Given this list of marker genes Mndal, Ifit3, Ppa1, H2-T22, Tapbpl, H2-T23, Tap2, Gbp5, Rnf114, Ube2l6, Irf1, AI987944, Lgals3bp, Xaf1, Cops3, Isg15, Igtp, Irf8, Samhd1, Tmem128, Socs1, Phtf2, Apobec3, H2-D1, Gbp6, Gbp3, Nmi, Serpina3g, Ifit1bl1, Irgm2, Tmsb10, Isg20, Psme2b, Ifi27l2a, Plaat3, Ifi47, Parp14, Stat1, Gbp8, Stat2, H2-Q4, Psmb10, Gbp9, Usp18, Bst2, Gimap3, Gimap4, Gbp4, Ly6e (NCBI Gene Id 17069), Phf11b, Gbp7, Irf7, Ifi213, Psme1, Idnk, Psmb9, H2-K1, Ifit1, Dbnl, Iigp1, Calhm6, Evl, Zbp1, Arl6ip5, B2m, Gbp2 (guanylate binding protein 2), Rnf213, Irgm1, Psme2, Tspan3, Psmb8, Irf9, Dtx3l, Cwf19l2, Tap1, Ifi206, Tapbp (NCBI Gene Id 28066), Parp9, Ly6a, here is a description of the gene set: Genes positively differentially expressed in cell type: Treg upon treatment with cytokine: IFN-γ in mouse lymph nodes in vivo. Mouse Gene Set: CUI_TREG_IFNG_RESPONSE_UP Cytokines mediate cell-cell communication in the immune system and represent important therapeutic targets. A myriad of studies have highlighted their central role in immune function, yet we lack a global view of the cellular responses of each immune cell type to each cytokine. To address this gap, the authors created the Immune Dictionary, a compendium of single-cell transcriptomic profiles of more than 17 immune cell types in response to each of 86 cytokines (>1,400 cytokine-cell type combinations) in mouse lymph nodes in vivo. A cytokine-centric view of the dictionary revealed that most cytokines induce highly cell-type-specific responses. For example, the inflammatory cytokine interleukin-1β induces distinct gene programmes in almost every cell type. A cell-type-centric view of the dictionary identified more than 66 cytokine-driven cellular polarization states across immune cell types, including previously uncharacterized states such as an interleukin-18-induced polyfunctional natural killer cell state. studied in species Mus musculus from publication Cui A, Huang T, Li S, Ma A, Pérez JL, Sander C, Keskin DB, Wu CJ, Fraenkel E, Hacohen N (PMID 38057668)